The following is a description of a gene set: Mouse Gene Set: REACTOME_METABOLISM_OF_NITRIC_OXIDE_NOS3_ACTIVATION_AND_REGULATION studied in species Mus musculus Metabolism of nitric oxide: NOS3 activation and regulation, and this is the list of marker genes: Nosip, Cav1, Ddah1 (dimethylarginine dimethylaminohydrolase 1), Cyb5b, Hsp90aa1, Zdhhc21, Nos3, Cygb, Calm1, Dnm2 (dynamin 2), Akt1, Lypla1, Nostrin, Calm3, Calm2 (calmodulin 2), Spr